Given this list of marker genes BAMBI, ADGRG6, WDR45B, NUP93, ST3GAL5, KYNU, SSBP1, APEX1, CHAF1A, CAD, CYB5B, DDX39A, AURKB, CAP2, ILF3, FAT1, PLK1, CDK5R1, SEMA3C, SYNM, DKK4, RPS26, CCNB1, CAV1 (caveolin 1), PROCR (protein C receptor), PWP1, PLAT, IFT25, FADD, PAX9, RPA3, UBE2C, HTR2A, SNRPF, ARHGDIG, MAGEA4, KDM5C, MAGEA2, SGCE, UCK2, DLEC1 (DLEC1 cilia and flagella associated protein), PSMA4, SPP1, PRPF19, PIGC, SOX10, NFE2L2, SNX1, ACTN1, PDGFRA, PLOD2, RRP1B, PRB4, ARPC4, VSNL1, TYR, AMELX, SCAMP5, AGPAT2, LSM1, ANXA2, CCND3, S100A11, MCRS1, ZPR1, CXCL1, RIBC2, MAT1A, NUP50, TMEM106C, TYMS, HAP1, TCF12, ST3GAL4, COPS3, CLDN9 (NCBI Gene Id 9080), TNFRSF25, ETV5, EMP2, ZKSCAN3, QPCT, PDLIM4, CD8B, TIMP2, GNG12, SLC22A18AS, PLK2, PKMYT1, TRIP6, ASNS, CASP2, PFKFB2, AHCY, SLC2A1, AEBP1, KCND3, PLEC, SRP19, NPC1, NEURL1, SYNGR4, TPM2, KRT86, DDX21, CST7, SERPINE1, TMX1, EMP3, RBBP8, PTS, NHP2, ITGB5, GTSE1, WWTR1, ITGA3, PRELID3A, DDIT4 (NCBI Gene Id 54541), FDFT1, WIZ, IRF5, ORC1, GMFB, JARID2, PSMD14, CDC20, E2F1, MMP1, NR1D1, AANAT, ARID1A (NCBI Gene Id 8289), TM4SF1, CD44, TBX1, PIGR, CD151, CSTF3, M6PR, SNRPB2 (NCBI Gene Id 6629), FN1, PIGA, ATP1B2, RFC4, HTATIP2, ACOT2, TRIP13, HTRA2 (HtrA serine peptidase 2), TK1, MTUS1, YWHAE, PLIN2, NFKBIB, DNMT1 (NCBI Gene Id 1786), SLC26A2, FABP7, STMN1, APOBEC3B, ELOVL2, GYG1, MCM2, COL9A3, BOP1, PHF10, TFDP1, COL4A1, TYRO3, PPT2, SLC5A2, DLGAP5, DHRS3, VBP1, HSPB2, CADM1, CDYL, COX7B, ADD2, IFIT1, VEGFA, SEC23A, SHROOM2, PCLAF (PCNA clamp associated factor), TRIB2, ITPR3, IFI16, AP1M1, GCLM, TIMP3, RCAN1, HOXB2 (homeobox B2), KIFC1, ACR, RO60, ALAS2, CRYBA4, CBX3, GJB1, GULP1, MDC1, MSX1, CXCL8, PLSCR1, TFAP2A, ARPC1A, OGG1, RND3, CALU, PITPNB, IGSF3, PSG7, KIF11, SERBP1, ITSN1, LGR5, EPB41L3 (erythrocyte membrane protein band 4.1 like 3), ITGA6, METAP1, MAGEA3, GPA33, TCF7, POLA2, EEF1E1, SLC7A11, ACOT7, IKBKG, GPNMB, SHMT2, IFRD2, FLNA, MTHFD1, LPCAT1, PTP4A1, CIAPIN1, SMAD3, CDC42EP1, EPAS1, NQO1, RAC2, CNN3, SLC43A1, SMPDL3B, GGH, ACKR2, MCM7, PLP1, RPA1, PMF1, EFNA2, MRPL3, POLE3, CDC34, LSM4, TNC, MLLT11, LAIR1, TFRC, NRG2, COPS8, GMPS, CKAP5, NUTF2, BTG3, GPR161, MAPK6, FOXM1, PIR, CNP, PTPN9, DOLK, FEN1, CDA, HAT1, EIF4EBP1 (eukaryotic translation initiation factor 4E binding protein 1), SFRP1, ODF1, ANGPT1, EPS8, MAD2L1, HPRT1, HNRNPA0, RCC1, PSMC4, LAMP2, BUB1B, CSNK2A1, DEGS1, ANXA1, KRT18, IER3, RCN2, SEMA3F, THBS2, PHLDA2, ITPA, CHST1, PXN, SLBP, SLC1A5, H2AX, EIF2S3, IPO5, S100A4, HMGN4, NPAS1, TNFRSF10B, PPP5C, SYNCRIP, PTTG1, CENPA, LY6G6C, TOP2A, CDC123, FDPS, TCAP, AK2, MYC, DOK1, MAPRE1, PRCC, RAC3, HTR3A, SDC1, SRPX, CYP4B1, DUSP4, TOR1AIP1, SMTN, CCT6A, VAT1, LMNB2, SNRPC, GAS1, CDKN2C, COPS2, INTS1, INHBC, SSR1, SLC4A2, KRT4, H2BC12, GDF15, SLC7A5, TNPO1, DYNLT3, H4C3, FEV, GAGE12F, MAP2K3, CTSC, TWF1, MACIR, CEP250, BMP1, SERPINH1, TPX2 (NCBI Gene Id 23477), PRSS23, CARD10, FHL2, HEG1, PCNA (NCBI Gene Id 5111), ST6GALNAC4, CCNF, ADSL (adenylosuccinate lyase), ACSL3, RRM1, SLC39A6, SLC39A7, ESPL1, TRIM16 (NCBI Gene Id 10626), PSMD4, CRIM1, ICMT, FDXR, PER1, NUP205, CDK2, TTLL12, CSE1L, CDK1, PCOLCE, GNG11, NOLC1, TGIF1, PRAME, PSMC6, C5orf15, PRKDC, PEG10, CIAO1, ZIC2, GBE1, CBX1, TRAM2, IGF2BP3, SMS, TMED3, TNF, ERBB3, NTSR2, TBX19, CHST3, CCNA2, PAICS, ABCF1 (ATP binding cassette subfamily F member 1), LPGAT1, UNG, EHMT2, TSPAN3, ZWINT, MOXD1, SRSF2, CDKN1C, SLC16A3, NUP153, DUSP6, PSMC2 (NCBI Gene Id 5701), ALDH1A3, CDH2, PDIA4, HTR7, RFC3 (NCBI Gene Id 5983), FKBP9, IARS2, TOMM34, MRPL12, SLC1A4, MFAP2 (NCBI Gene Id 4237), IRAK1, LAMB1, DTYMK, ANPEP, AP3B1, LEF1, MME (NCBI Gene Id 4311), NUDT1, CD22, HTR4, LMNB1, ITGA2B, MYO10, GYPB, MSH6, RAP1A, VSIG4, AIMP2, COL2A1, PTP4A3, POU4F1, ATP1A1, TRIM2, MCM6, TPM1, CKS2, here is a description of the gene set: Human Gene Set: MODULE_18 Genes in the cancer module 18. species: Homo sapiens